Given this list of marker genes Eif2b1, Utp18, Plscr4, Igf2r (insulin-like growth factor 2 receptor), Aste1, Frs2, Urod, Zfp931, Dvl3, Prkab2, Pa2g4, Tmem181a, Wdr4, Spata6, Ptges2, Trpt1, Dync2i2, Tom1, Srbd1, Tbc1d23, Zfp35 (NCBI Gene Id 22694), Slc4a8, Armc6, Tifa, Nmrk1, Fbxl18, Tns3, Srp68, here is a description of the gene set: Cytokines mediate cell-cell communication in the immune system and represent important therapeutic targets. A myriad of studies have highlighted their central role in immune function, yet we lack a global view of the cellular responses of each immune cell type to each cytokine. To address this gap, the authors created the Immune Dictionary, a compendium of single-cell transcriptomic profiles of more than 17 immune cell types in response to each of 86 cytokines (>1,400 cytokine-cell type combinations) in mouse lymph nodes in vivo. A cytokine-centric view of the dictionary revealed that most cytokines induce highly cell-type-specific responses. For example, the inflammatory cytokine interleukin-1β induces distinct gene programmes in almost every cell type. A cell-type-centric view of the dictionary identified more than 66 cytokine-driven cellular polarization states across immune cell types, including previously uncharacterized states such as an interleukin-18-induced polyfunctional natural killer cell state. from publication Cui A, Huang T, Li S, Ma A, Pérez JL, Sander C, Keskin DB, Wu CJ, Fraenkel E, Hacohen N (PMID 38057668) Genes positively differentially expressed in cell type: ILC (innate lymphoid cell) upon treatment with cytokine: TRAIL in mouse lymph nodes in vivo. Mouse Gene Set: CUI_ILC_TRAIL_RESPONSE_UP species: Mus musculus